The following is a description of a gene set: species: Homo sapiens Any process that modulates the frequency, rate, or extent of a process that reduces the internal pH of a cell. Human Gene Set: GOBP_REGULATION_OF_CELLULAR_PH_REDUCTION, and this is the list of marker genes: UBE3A, CA7, SLC9A8, CA2, AVPR1A, AVP (NCBI Gene Id 551), BCL2, SLC9A7